The following is a description of a gene set: studied in species Mus musculus Genes predicted to be targets of miRBase v22 microRNA mmu_miR_7000_5p in miRDB v6.0 with MirTarget v4 prediction scores > 80 (high confidence targets). Mouse Gene Set: MIR_7000_5P from publication Chen Y, Wang X (PMID 31504780), and this is the list of marker genes: Plxnd1, Prl5a1, 4930523C07Rik, Tram1 (NCBI Gene Id 72265), Fnbp1, Sox6, Stag3, Echdc1, Krtap4-7, Rai14, Itga9, Tsr2, Pacsin1, Zfp39, Iffo2, Hipk1, Map3k9, Gpr173, Ikzf4, R3hdm4, Nos1, Rbms3, Prrc2b, Npbwr1, Scn7a, Cdkl3, Spx, Cwc15, Tmem179, Bcl2l13, Dchs1, Kbtbd11, Smarca1, Dlg3, Pdxp, Cdc37, Syk, Mlxip, Foxn1, Gcsam, Nfic, Gnao1, Aoc3, Ambn, Astl, Lrch4 (leucine-rich repeats and calponin homology (CH) domain containing 4), Spata31d1c, Sdc3, Gnal, Pip5k1c, Fam168a, Slc12a9, Ankfn1, Vegfa, Sypl2, Zfp629, Slc7a1, Usp5, Mmp24, Tarbp1, Dtx4, Fgf9, Plxna1, Sema4c, Fosl2, Ankrd63, Atcay, Foxo4, Shisal1, Clip3, Spata7, Cbx5, Acot7, Anks1, Fgfr2, Pigm (phosphatidylinositol glycan anchor biosynthesis, class M), Ccnq, Rab5b, Capn5, Ifnlr1, Zfp207, Celf5, Csgalnact2, Fut8, L3mbtl4, Mecom, Phf19, Slc4a8, Slc12a5, Slc6a11, Wnt9b, Vil1, Cpne7 (copine VII), Smg7, Grhl2, Cic, Ascl4, Igsf9b, Tmem25, Ak5 (NCBI Gene Id 229949), Cplx2, Sfxn5, L1cam, Sox13, Ptger4, G3bp2